The following is a description of a gene set: Mouse Gene Set: GOBP_ANOIKIS studied in species Mus musculus Apoptosis triggered by inadequate or inappropriate adherence to substrate e.g. after disruption of the interactions between normal epithelial cells and the extracellular matrix., and this is the list of marker genes: Pdk4, E2f1, Mybbp1a, Tle5, Mcl1, Sik1, Bcl2l1, Clca3a2, Map3k7, Ptk2, Itga5 (integrin alpha 5 (fibronectin receptor alpha)), Ikbkg, Brms1, Pik3ca, Itgb1, Ptrh2, Bmf, Cryba1, Src, Stk11, Cav1, Tfdp1, Tsc2, Ntrk2, Snai2, Dapk2 (NCBI Gene Id 13143), Tle1 (transducin-like enhancer of split 1), Chek2, Ankrd13c, Notch1, Bcl2